The following is a description of a gene set: species: Homo sapiens The cell cycle process in which sister chromatids are organized and then physically separated and apportioned to two or more sets. Human Gene Set: GOBP_SISTER_CHROMATID_SEGREGATION, and this is the list of marker genes: DCTN2, SMARCE1, INO80, ZW10, FLNA, BCL7A, RCC1 (NCBI Gene Id 751867), CDC6, ANAPC1, TEX14, MAP3K20, SMARCD1, CDC23, CENPK, UBE2C, NCAPD2, NEK6, CDK5RAP2, CHMP1B, KLHL22, MIS12, TACC3, SMARCB1, CHFR, TPR, PSMG2, ANAPC5, KATNB1, INCENP, CHEK2, RHOA, CENPI, SMARCA5, DLGAP5, PSRC1, BECN1, MYBL2, CENPF, TPX2, NSL1, NCAPD3, KIF2C, BRD7, SMC2, MOS, POLDIP2, KNSTRN (kinetochore localized astrin (SPAG5) binding protein), CCDC61, CDT1, DRG1, TUBG2 (NCBI Gene Id 27175), CDCA8, EML4, BCL7C, SMARCA4, PPP2R1A, MAD2L2, KAT2B, PRICKLE1, CEP55, RANGRF, AAAS, NSMCE2, ATM, ANAPC2, CENPE, CCSAP, HNRNPU, RACGAP1, ANAPC7, RIPOR2, RRS1, MAD2L1BP, MAP10, HSPA1B, ACTL6B, TTN, CHMP4C, SMARCC2, SKA1, CHMP2A, BOD1, KIF22, CHMP3, ESPL1, SMARCC1, AKAP8, GEN1, PHF10, BCL7B, DIS3L2, RAN, PHF13, TTK, KPNB1, NCAPH2, LSM14A, TOP2A, KAT5, CEP97, AURKC, NUDC, NIPBL, TUBG1, KIF14, KIF23 (kinesin family member 23), SPICE1, KNL1, PRAP1, LCMT1, SPC24, CCDC66, TRIP13 (thyroid hormone receptor interactor 13), PBRM1, USP44, KIF3B, SMARCD2, WRAP73, BAZ1B, BUB1, ANAPC4, VPS4A, ABRAXAS1, RAD21, MISP, AURKB, SMC1A, CCNB1, IK, PIBF1, KNTC1, MAD1L1, AKAP8L, NUMA1, FBXO5, SIRT1, ZWINT, LATS1, PRP4K, VPS4B, PINX1, SMC4, NCAPG2, KIF4A, KIF2A, BCCIP, CHMP2B, CHMP1A, RIOK2, DPF2, GOLGA2, DPF1, ABRAXAS2 (abraxas 2, BRISC complex subunit), CUL3, NEK2, ARID2, DYNC1LI1, KIFC1, WAPL, KIF18A, CHMP6, CHMP5, MZT1, ZWILCH, HECW2, SPC25, CDC16, CHMP4BP1, CDCA5, CDC20, CEP192, PDCD6IP, H2BW1, TOP2B (NCBI Gene Id 7155), SPAG5, KIF15, CLASP1, SEH1L, DUSP1, ZNF207, XRCC3, CENPC, SMARCA2 (NCBI Gene Id 95083), CHMP4B, ACTB, RMI2, NCAPG, TENT4A, SPDL1, DPF3, KIF11, NDC80 (NCBI Gene Id 10403, NDC80 kinetochore complex component), ARID1A, STAG1 (STAG1 cohesin complex component), MAP9, RAB11A, STAG2, RMDN1, CHMP4A, NUF2, CDK1, NUP62, MAPRE1, KMT5A, BUB3, KIF4B, ARID1B, BUB1B, UHRF1, ACTL6A, HSPA1A, MAD2L1, SKA3, CDC27, CLASP2, MAPK15, KIF18B (NCBI Gene Id 146909), EML3, PPP1CC (protein phosphatase 1 catalytic subunit gamma), SKA2, RB1, ANKRD53, HASPIN, APC, ANAPC15, BIRC5, NCAPH, SMC3, ARHGEF10, CHAMP1, SMARCD3, PRC1, OFD1, PLK1 (NCBI Gene Id 5347), CHMP7, NUSAP1, ANAPC11, KIF25